The following is a description of a gene set: Mouse Gene Set: GOMF_TRANSITION_METAL_ION_TRANSMEMBRANE_TRANSPORTER_ACTIVITY Enables the transfer of transition metal ions from one side of a membrane to the other. A transition metal is an element whose atom has an incomplete d-subshell of extranuclear electrons, or which gives rise to a cation or cations with an incomplete d-subshell. Transition metals often have more than one valency state. Biologically relevant transition metals include vanadium, manganese, iron, copper, cobalt, nickel, molybdenum and silver. species: Mus musculus, and this is the list of marker genes: Slc39a13 (solute carrier family 39 (metal ion transporter), member 13), Atp2c1, Slc40a1, Hamp, Tfrc, Slc30a6, Mmgt2, Slc30a9, Slc31a2 (NCBI Gene Id 20530), Slc39a9, Slc39a3, Slc30a5, Slc25a37, Trpm2, Mcoln2, Mmgt1, Slc39a2, Slc39a10, Slc30a2, Atp2c2, Slc30a10, Trpm7 (NCBI Gene Id 80648), Slc11a1, Slc39a7, Atp7b, Slc30a3, Atp7a, Tmem165, Slc39a11, Slc30a8, Slc30a7 (NCBI Gene Id 99654), Slc30a4, Slc25a28, Slc11a2, Slc39a8, Mcoln1, Slc30a1, Slc46a3 (NCBI Gene Id 71706), Hamp2, Slc39a4, Slc39a12, Slc39a6, Slc39a5, Slc39a14, Slc31a1, Slc39a1